The following is a description of a gene set: A process that initiates the activity of an inactive store-operated calcium channel. Mouse Gene Set: GOBP_ACTIVATION_OF_STORE_OPERATED_CALCIUM_CHANNEL_ACTIVITY species: Mus musculus, and this is the list of marker genes: Asph, Stimate, Plcg2, Cracr2a, Stim2, Stim1